Given this list of marker genes Nab1, Faap24, Slc25a46, Hycc2, Atp2c1, Epha4, Pygo1, Rc3h2, Atrx, Fmo9, Emc1, Naf1, 2310039H08Rik, Cxxc4, Ap3s1, Serpinb13, Eif1ad3, Calhm5, Kcnk10, Atrnl1, Sestd1, Acbd5, Mob1a, Prpf4b, Eif1ad7, Fam168a, Gatm, Sft2d3, Eid2b, Cenpu, Mblac2, Rcor1, Cyp2c50, Pls3, Rad51b, Raver2, Loxl2, Tab3, Abcd2, Akap8, Cdk6, Kras, Tex13c1, Bhlhb9, Klf13, Hps3, Osbpl11, Eif1a, Smarcc1, Crppa, Srrm2, Slc10a2, Rab11a, Frs2, Sub1, Cep97, Nkd1, here is a description of the gene set: from publication Chen Y, Wang X (PMID 31504780) species: Mus musculus Genes predicted to be targets of miRBase v22 microRNA mmu_miR_532_5p in miRDB v6.0 with MirTarget v4 prediction scores > 80 (high confidence targets). Mouse Gene Set: MIR_532_5P